Given this list of marker genes CELSR2, ST7L, ABCA7, PAK1IP1, ABCB8, INA, ZNF160, MIS18A, DNAH11, DOCK1, HMGN2, GPD1, CRY1, H3C4, PTH1R, ETV5, MIF4GD, IL1RL1, RMDN3, INPP5B, PLEKHB2 (pleckstrin homology domain containing B2), ACBD6, CHCHD6, NUP214, SHLD2, YTHDF2, FNTB, DGAT2, CSF1R, TAF7, PAPOLA, PCK1, PECAM1, ZC3H3, FBXL3, TRPM1, NDUFAF3 (NCBI Gene Id 375340), UQCC2, TPT1, ACP2, WNT2, NR1H3, SOD1, DIPK2B, FLNA, SARS1, RSF1, ASB16, HLA-DRB4, NUP88, ELN, KDM7A, ARSA, LRRC40, PKD1, ACVRL1, CHAMP1, ZNF106, ZNF559, SLC12A5, PHYHIP, here is a description of the gene set: Human Gene Set: MODULE_256 Genes in the cancer module 256. studied in species Homo sapiens